Given this list of marker genes HSD17B4, FADS1, ABCD1, ACSL1, ELOVL5, ACOT8, ACOX1, ELOVL3, ELOVL2, ACAA1, SCP2, FADS2, ELOVL1, here is a description of the gene set: part of: alpha-linolenic (omega3) and linoleic (omega6) acid metabolism Reactome Pathway: alpha-linolenic acid (ALA) metabolism Alpha-linolenic acid (ALA, 18:3(n-3)) is an omega-3 fatty acid, supplied through diet as it cannot be synthesized by humans. ALA has an important role in human health. It is converted to long chain more unsaturated n-3 fatty acids by a series of alternating desaturation and elongation reactions. Omega-3 products of ALA such as eicosapentaenoic acid (EPA) and docosahexaenoic acid (DHA) reduce inflammation and may help lower risk of chronic diseases, such as heart disease and arthritis. All the desaturation and elongation steps occur in the endoplasmic reticulum (ER) except for the final step which requires translocation to peroxisomes for partial beta-oxidation.<br><br>The alpha-linolenic acid pathway involves the following steps: 18:3(n-3)--> 18:4(n-3)-->20:4(n-3)-->20:5(n-3)-->22:5(n-3)-->24:5(n-3)-->24:6(n-3)-->22:6(n-3). Two desaturation enzymes are involved in this process: delta-6 desaturase that converts 18:3(n-3) to 18:4(n-3) and 24:5(n-3) to 24:6(n-3) respectively, delta-5 desaturase 20:4(n-3) to 20:5(n-3).. studied in species Homo sapiens